Given this list of marker genes POLE, CHFR, MMP17, GALNT9 (NCBI Gene Id 729185), PUS1, ULK1, EP400, P2RX2, SFSWAP, PGAM5, NOC4L, GOLGA3, DDX51, PXMP2, ANKLE2, here is a description of the gene set: from publication Nikolsky Y, Sviridov E, Yao J, Dosymbekov D, Ustyansky V, Kaznacheev V, Dezso Z, Mulvey L, Macconaill LE, Winckler W, Serebryiskaya T, Nikolskaya T, Polyak K (PMID 19010930) A single cancer cell contains large numbers of genetic alterations that in combination create the malignant phenotype. However, whether amplified and mutated genes form functional and physical interaction networks that could explain the selection for cells with combined alterations is unknown. To investigate this issue, we characterized copy number alterations in 191 breast tumors using dense single nucleotide polymorphism arrays and identified genes with copy number gain organized into 30 amplicons. Amplicons were distributed unequally throughout the genome. Each amplicon had distinct enrichment pattern in pathways, networks, and molecular functions, but genes within individual amplicons did not form coherent functional units. Genes in amplicons included all major tumorigenic pathways and were highly enriched in breast cancer-causative genes. In contrast, genes with somatic mutations in breast cancer were distributed randomly over the genome, did not represent a functionally cohesive gene set, and were relatively less enriched in breast cancer marker genes. Mutated and gained genes did not show statistically significant overlap but were highly synergistic in populating key tumorigenic pathways including transforming growth factor beta, WNT, fibroblast growth factor, and PIP3 signaling. In general, mutated genes were more frequently upstream of gained genes in transcription regulation signaling than vice versa, suggesting that mutated genes are mainly regulators, whereas gained genes are mostly regulated. ESR1 was the major transcription factor regulating amplified but not mutated genes. Our results support the hypothesis that multiple genetic events, including copy number gains and somatic mutations, are necessary for establishing the malignant cell phenotype. Human Gene Set: NIKOLSKY_BREAST_CANCER_12Q24_AMPLICON Genes within amplicon 12q24 identified in a copy number alterations study of 191 breast tumor samples. species: Homo sapiens